Given this list of marker genes B3GAT3, TFE3, PUF60, TMEM63A, ZBTB7A, PRR12, GPR156, ZMYM2 (NCBI Gene Id 7750), PDE6H, SOX9, RHOA, ADAMTS17, LOX (NCBI Gene Id 4015), BBS9, USP7, ARSG, ARCN1, MSX2, PIGT, DPH5, XYLT1, UBAP2L, BBS1 (Bardet-Biedl syndrome 1), TASP1, TBC1D24, FKRP, CLP1, CYSLTR2, BPTF, AIFM1, NCF1, USP45, COL12A1, RAD51C (RAD51 paralog C), CBS, EDEM3, GTPBP2, TULP1, IMPDH1 (NCBI Gene Id 6105), SNORD115-1, CHD4, IARS2, COL18A1, TSPAN7, YME1L1, VCAN, AFF4, EFEMP1, LRMDA, SCLT1, GJA5, FN1, SLC35A2, COL8A2, XYLT2, WAC, CEP290, MAG, ASPH, HNRNPR, CHM, TUB, FGFR3 (fibroblast growth factor receptor 3), VSX1, KCNE5, CNGB3, LOXL3, CAMK2B, NYX, VPS13B, ANKRD11, AARS1, TCF4, TAF4, POGZ, SIX6, MAPK8IP3, GDF6, PGM2L1, DAG1, SYT1, BRCA2, ATP6V1E1, H4C3, ERCC4, CACNA1G, UBE3B, KCNJ13, ATRX (ATRX chromatin remodeler), THG1L, PDZD8, BUD23, SHOC2, PPP2R5D, DOHH, RAD50, PIGW, TBC1D7, ADAMTS10, BRAF, CTNNB1, CRYGC, RAX, GTF2H5, NSD1 (NCBI Gene Id 6797), PTPN11 (protein tyrosine phosphatase non-receptor type 11), NEUROD2, WHRN, IFIH1, COL25A1, HNRNPK, ERCC3, AKT1, SLC6A8, TRIM37, RRAS2 (NCBI Gene Id 22800), SMARCAL1, SPATA7, ARHGEF2, KIF21A, PDGFRB, NDP, GUCY2D, ZMIZ1, ATP6AP1, CFAP418, CHD6, KLLN, PLOD1, RNF113A, EXOSC5, RP1, SKI, METTL27, TGM5, CIB2, FOXL2, ELOVL4, KRAS, RPL10, CLDN19, RLBP1, HDAC4, HCCS, ZMYM3, GRIA1, FANCG, ALDH18A1, FGF3, EED, ERI1, ADAMTS18, B4GALT1, GNB2, PIGQ, ZEB2, PPP1R21, UCHL1, CNGA3, CRPPA, INTS1, PDE6C (phosphodiesterase 6C), PAK2, BBS5, ADAMTSL4, GRK1, MAGEL2, WDR35, TRIT1, CRB1, MIR184, TUBB2B, ARID1A, FLII, IFT43, AMMECR1, FLCN, PITX2, RPGR, PURA, TKFC, VPS37D, CHD3 (NCBI Gene Id 1107), RAI1, MYT1L, PLOD3, UNC119, GJA1, TUBA1A, GRM6, TOMM7, NBAS, WDR26, SOX4, IQSEC2, PRDM5, MED25, DDX6, MYO5A, NPAP1, POMT1, KAT5, CRYBA4, ADNP, ARID2, ROBO1, PIGU, ACSL4, NT5C2, SCUBE3, SMAD4, AP1G1, TCF20, PRIMPOL, NR2F1, KIDINS220, PAX6, STXBP1, COL2A1, MAP2K2, GLE1, AGK, KDM5B, TEAD1, CDH23, SETBP1, SMC1A, CHST3, OTUD5, B4GALT7 (beta-1,4-galactosyltransferase 7), CPSF1, EBF3, GNAQ, SNORD116-1, PBX1, OPN1MW, CENPT, PIGA, RAB28, TFAP2A, COL4A5, TARS1, STX1A, GNAT2, AHDC1 (AT-hook DNA binding motif containing 1), CHST14, PRPS1, TTLL5, COL3A1, CLDN16, RPE65, CLDN11, MAP3K7, COL4A3, GTF2IRD1, RHO, KCNAB2, KIF11, PRDM16, SMARCA4, USF3, PSMD12, RFC2, SLX4, TBC1D23, MED12, CASK, OGT, SATB2, SMARCE1, LTBP2, WDR19, FANCB, CSGALNACT1, PPOX, RAD21, LAS1L, COL9A1, CRYGD, TFAP2B, CRYAB, PHIP, SMC3, CACNA2D4, HSPG2, NADK2, CAMSAP1, TBCE, ZNF148, CRIPT, ADGRL1, FKBP6, CHRDL1, P4HA2, VARS1 (valyl-tRNA synthetase 1), TMEM98, IQCB1, EIF4H, GPR179, MPLKIP, GATAD2B, SNRPN, SEC23B, MKS1, GJA8, LAMB2, CDC45, TMEM270, EPRS1, AEBP1, BRIP1, BAP1, AP1B1, ZNF408, EPHA2, HADHA, MBD5 (NCBI Gene Id 55777), HGD, TWIST2, PQBP1, FOXP1, MFRP, ARPC4, SOBP, SLC25A24, ATF6, P4HTM, CREBBP, RS1, BBS2, EHMT1, DNAJC30, C12orf57, NOG, RPGRIP1, CTSK, IGF1, YY1, TUBB4B, ZNF469, USH2A, SOX5, SDHD, OTX2, TAF1, DNAJC21, RECQL4, HERC1, B3GALNT2, PIGG, DPAGT1, BAZ1B, SMARCB1, PAX2, CHST6, UBE4B, JAG1, LIMK1, POLR1C, MC1R, B3GLCT, CCDC47, ATP6V1A, ASXL3, SATB1, PRSS56, MAN1B1, SDHB, BBIP1, ARR3, BBS7, UQCC3, RAP1B, RNF2, TTR, WDR45, GTF2E2, ANTXR1, POMK, SLC39A5, USP9X, MID1, KRT14, ITPR1, SLC38A8, BRCA1, FANCA, POC1B, GRHL2, FANCC, COX7B, LRIT3 (NCBI Gene Id 345193), CAMK2G, NRAS, LRP2 (LDL receptor related protein 2), CYP4V2, HK1, MKRN3, NFIX, TLK2, SON, FAM111A, PIGL, CDK8, SDCCAG8, MLXIPL, TRPV4, RBM10, LAMA1, SLC24A1, BLOC1S3, RP2, GALNT2, ARL6, COL4A1, HACE1, PACS1, MKKS, PGAP3, ROBO3, MFSD8, ACOX1, CHMP1A, FANCM, FKBP14, MADD, THOC6, PIGY, TCEAL1, GNPTAB, CRELD1, SPTSSA, ARV1, MED13L, FBXO11, ASCC3, IFT52, LRP5, KCNV2, TAOK1, PACS2, SLC25A4, KRT5, ELN, CARS1, PRKAR1B, COL9A2, H1-4, CABP4, ATAD3A, GNB3, TTC8, DEAF1, BFSP2, FGD1, SETD5, PMM2, SAG, BMP4, ASH1L, PDPN, HS6ST2, FBN2, POLR3GL, MANF, COL1A2, H4C5, NDRG1, OPTN, ARID1B, FZD4, NPR3, MAN2B1, LMBRD2 (NCBI Gene Id 92255), PDZD7, ZFX, SCAPER, AIPL1, SOX10, B3GALT6, GABRD, IFT122, RD3, CLCN3, SLC2A10, NMNAT1, CTCF, TCTN2, LMX1B, HIVEP2, NEDD4L, ATP6V1B2, CAMTA1, HERC2, CRYBB1, BRD4, ALDH3A2, LCA5, CRYBB2, SLC4A11, MAF, AGBL5, SIN3A (SIN3 transcription regulator family member A), CLRN1, KAT8, IFT140, HDAC8, ASXL1, IRX5, ACBD6, MYO1H, OFD1, DSE, FANCL, OVOL2, CCDC28B, COL11A2, UBE2T, POLR3B, MED12L, CAPRIN1, DYRK1A, MMP23B, SRCAP, MYO7A, SF3B1, GPAA1, PIGV, TRIM32, POMT2, NEK1, FGFR2, TAF6, IFT74 (NCBI Gene Id 80173), SMS, KIAA0586, CC2D2A (coiled-coil and C2 domain containing 2A), TMEM94, TRNT1, SLC39A8, NOTCH2, COL17A1, IFT27, IPO8, GMPPB, TIMM8A, PHOX2A, UBE3A (NCBI Gene Id 7337, ubiquitin protein ligase E3A), CCNQ, XRCC2, PCYT1A, CYP1B1, PTEN, MAD2L2, RAD51, BEST1, NDUFB11, ABCC6, BCL11B, SYNE1, SRRM2, RAB11B, GLRA2, KIFBP, CEP78, PEX11B, ERCC2, FANCF, LUZP1, FZD5, WDPCP, GZF1, FBXW11, USH1G, TUBB3, ADAMTS2, CEP19 (NCBI Gene Id 84984), NPHP1, PPM1D, TBL2, CACNA1F, EFL1, INTS11, SOX11, TBC1D2B, EP300 (NCBI Gene Id 2033), HARS1, KERA, KIAA0753 (NCBI Gene Id 9851), NIPBL, C1QBP, COL11A1, TRAPPC11, LZTFL1, EMC1, NALCN, COL4A4, OPN1LW, USH1C, FANCD2, SOX2, SLC6A6, PNPLA6, FBXW7, PCNT, CSPP1 (centrosome and spindle pole associated protein 1), EXOSC2, CSTA, TGFBI, PWAR1, NONO, TRPM1, PIK3CA, SLITRK6, PIEZO2, ERMARD, CRYBA2 (crystallin beta A2), CANT1, FBN1, KANSL1, RERE, EIF2S3, KMT2B, P3H2, GNAT1, TEK, OAT, GJC2, LRRC32, KAT6A, ERBB3, ZSWIM6, RDH12, MBTPS2, SLC12A6, PALB2, ALDH1A3, RMRP, TYR, APC2, POMGNT1, MAP2K1, SDHC, GNPTG, ELP1, RFWD3, PWRN1, OCA2, PPP1R12A, ERCC8, GTF2IRD2, ZEB1, LRAT, PGAP2, DPYD, CRX, PIGO, LRPAP1, BLTP1, RORA (RAR related orphan receptor A), KCNH1, BBS4 (NCBI Gene Id 585), PRKCZ, UFC1, CASZ1, CRYAA, POLR3A, GLRB, CHAMP1, VPS50, SCO2, ZC4H2, SPEN, SMG8, LIG4, PDE6B, NSUN2, GTF2I, ZNF644, BICRA, COL9A3, MARK3, COL4A6, FKTN, AP3D1, GNA11, CLIP2, PIK3R1, RIN2, ADGRV1, GPR143, BBS12, KMT2C, ESPN, COL5A1, KDM5C, ERCC6, PCDH15, TDO2, PRMT7, RNU4ATAC, FANCE, CNOT3, FLNA, FANCI, SMARCC2, CNNM4, FIBP, LARGE1, RNU4-2, MT-TS2, ATP6V0A2, HUWE1, ADAMTSL1, SMARCD1, PDE4D, MYOC, BBS10, IFT172, TNPO2, HTT, DPF2, here is a description of the gene set: An abnormality in the process of focusing of light by the eye in order to produce a sharp image on the retina. Human Gene Set: HP_ABNORMALITY_OF_REFRACTION species: Homo sapiens Abnormality of refraction